Given this list of marker genes Ep300, Kat2b, Foxo3, Sirt1, Sirt3, Foxo1, here is a description of the gene set: Regulation of FOXO transcriptional activity by acetylation Mouse Gene Set: REACTOME_REGULATION_OF_FOXO_TRANSCRIPTIONAL_ACTIVITY_BY_ACETYLATION studied in species Mus musculus